Given this list of marker genes AMFR, SPRING1, PAQR3, MIR96, INSIG2, FBXW7, TMED2, ZBTB7B, INSIG1, here is a description of the gene set: Any process that modulates the frequency, rate or extent of the SREBP signaling pathway. species: Homo sapiens Human Gene Set: GOBP_REGULATION_OF_SREBP_SIGNALING_PATHWAY